Given this list of marker genes Cemip, Gnrhr, Pdgfrl, Ifit1, Npnt, Sfrp2, Id4, Ccl5, Rcan2, Asb5, Aspn, Hey1, Postn (periostin, osteoblast specific factor), Ptn, Rgcc, Hdac9, Tgfbi, Gas2, Svep1, Foxred2, Plb1, Ociad2, Pde10a, S100a10, C1s1, Cd34, Sulf1, Flrt3, Dnm3os, Clec11a, Has2, Adgre5, Kctd12, Ctbs, Ntn1, Cthrc1, Pdgfra, Ppig, Cxcl5, Adm, Man1c1, Fabp3, Yipf5, Adgrg2, Pcdhb9, Serpina3g, Slc38a4, Mtus2, Il7, Carns1, Clu, Il13ra1, Colec12, Sema3b, Enpp1, Akip1, Cdh11, Tbx20, Ints12, Egr3, Pmaip1, Tgtp1, Nipal4, Myo1b, Kctd12b, Cryab, Bend5, Gm15246, Epha1, Cdh3, Crip1, Cp, Gal3st4, Kdm6a, Islr, L1cam, Slc5a7, Medag, Hspa1b (NCBI Gene Id 15511), Tmt1a, Grb14, Abca1, Tmt1a2, Nudt7, Cyp7b1, Nrep, Lmcd1, Bves, Fos, Sorbs2, Serpinb6b, Atp1b1, Slc1a6, Rasl11a, Sfrp1 (secreted frizzled-related protein 1), Zc2hc1a, Rnf144b, Procr, Sorcs2, Kcnf1, Gca (grancalcin), Rab40b, Riox1, here is a description of the gene set: The reciprocal chromosomal translocation t(4;11) is correlated with infant, childhood, adult and therapy-related high-risk acute leukemia. Here, we investigated the biological effects of MLL.AF4, AF4.MLL or the combination of both reciprocal fusion proteins in a conditional in vitro cell culture model system. Several parameters like cell growth, cell cycling capacity, apoptotic behavior and growth transformation were investigated under physiological and stress conditions. Co-transfected cells displayed the highest resistance against apoptotic triggers, cell cycling capacity and loss-of-contact inhibition. These analyses were complemented by gene expression profiling experiments and specific gene signatures were established for each of the three cell lines. Interestingly, co-transfected cells strongly upregulate the homeobox gene Nanog. In combination with Oct4, the Nanog homeoprotein is steering maintenance of pluripotency and self-renewal in embryonic stem cells. Transcription of Nanog and other stem cell factors, like Oct4 and Bmi1, was verified in biopsy material of t(4;11) patient cells which express both reciprocal t(4;11) fusion genes. In conclusion, the presence of both reciprocal MLL fusion proteins confers biological properties known from t(4;11) leukemia, suggesting that each of the two fusion proteins contribute specific properties and, in combination, also synergistic effects to the leukemic phenotype. Up-regulated genes from the set E (Fig. 5a): specific signature shared by cells expressing either MLL-AF4 or AF4-MLL fusion proteins alone, and those expressing both fusion proteins. species: Mus musculus Mouse Gene Set: GAUSSMANN_MLL_AF4_FUSION_TARGETS_E_UP from publication Gaussmann A, Wenger T, Eberle I, Bursen A, Bracharz S, Herr I, Dingermann T, Marschalek R (PMID 17130830)